The following is a description of a gene set: The component of the presynaptic membrane consisting of gene products and protein complexes that are loosely bound to one of its surfaces, but not integrated into the hydrophobic region. studied in species Homo sapiens Human Gene Set: GOCC_EXTRINSIC_COMPONENT_OF_PRESYNAPTIC_MEMBRANE, and this is the list of marker genes: PICALM, AP2B1, C1QC, AP2M1, SNAP91 (synaptosome associated protein 91), C1QA, STXBP1, DNAJC6, CTNNA2